Given this list of marker genes CUL2, RPS6KA3, SPICE1, MED12, HLA-E, EIF4B, CD1B, POGZ, AP2A2, STARD5, ESYT1, IFNA16, SLC7A7, ITGAL, CBX5, PCNA, EIF2B5, SOCS7, ICAM3, ATP5PO, SLC1A5, POR, VAMP8, CSRP1, CCR1, BRD3, CDH2, FRY, VAT1, FCAR, TLE5, CPVL, NDUFV1, AHCY, INTS10, OGG1 (8-oxoguanine DNA glycosylase), COMT, GNRH2, VASH1, HLA-DMB, CLSTN1, SELENOP, POLE3, MNDA, ERCC3, RPL6, STK38, PTGS1, DNASE2, ADORA3, DIAPH1, PDE1C, ERF, CTDSP2, TRIO, ITGAM, DGKZ, MLEC, RPL22, HEXA, NASP, BRCA2, NISCH, ADIPOR2, KAT2A, UQCRC2, CD163, BLMH, DOK2, SORL1, PIP4K2A, AGA, DDX28 (NCBI Gene Id 55794), TACC1, CYFIP1, ALDH5A1, IMPA2, CCR5, MED22, LTB, TAF11, SPECC1L, FSHR, SUPT4H1, TDRD3, MTCL2, MYO7A, PDLIM7, CD1D, CD14, ERP29, CNOT3, HTT, POU2F1, SRSF3, ALDOC, UBXN1, CDK3, PADI2, MUC6, GPX3, HDDC2, B3GNT2, NPTN, LAIR2, PCBP2, FOS, BLOC1S1, TLR1, AMHR2, MEGF9, SNAPC5 (NCBI Gene Id 10302), ALDH3A2, AMPD2, SELE, FCGRT, METAP1, TKT, DAB2, PBX3, PREPL, P2RY14, RPS4Y1, CNPY3, CD27, EIF4EBP1, SDHB, H2AZ1, DDX39A, WDR1, ERCC1, P2RY11, YAF2, SNRPA1, LRP1, ABCA6, PER2, VSIG4, MSH3, C3AR1, SEC14L1, ZC3HAV1, PTPRCAP, DOCK2, ACTA2, SPINK4, SERPINB8, TXNIP, FAM20B, FGL2, GART, LTA4H, HMGN2, SF1, RDH11, SLC25A12, FAM168B, PLCG2, SEC11A, STAB1, OGT, ARHGEF6, PRCP, SYNE1, ANGPTL7 (NCBI Gene Id 149217), FEN1, NME4, GLB1, SF3A3, ADGRL2, KLF4, VAV1, CIAO1, LY6G6D, MCM3AP, PABPN1, KYAT1, S100A4, PIK3CG, AP1B1, OGA, SLC35A3, STX16, P2RY6, ANKS1A, BTD, DST (dystonin), PECAM1, POLR2H, FAM3A (NCBI Gene Id 60343), SNX27, HLA-DOA, MAX (MYC associated factor X), SPIB (Spi-B transcription factor), SLC43A1, SNRNP200, IRAG2, NCF4, PRKCB, CPE, here is a description of the gene set: species: Homo sapiens Genes down-regulated in comparison of dendritic cells (DC) exposed to L. donovani versus DCs exposed to 5 worm/well B. malayi. Human Gene Set: GSE360_L_DONOVANI_VS_B_MALAYI_LOW_DOSE_DC_DN from publication Chaussabel D, Semnani RT, McDowell MA, Sacks D, Sher A, Nutman TB (PMID 12663451) Monocyte-derived dendritic cells (DC) and macrophages (MΦ) generated in vitro from the same individual blood donors were exposed to five different pathogens, and gene expression profiles were assessed by microarray analysis. Responses to Mycobacterium tuberculosis and to phylogenetically distinct protozoan (Leishmania major, L. donovani, Toxoplasma gondii) and helminth (Brugia malayi) parasites were examined, each of which produces chronic infections in humans yet vary considerably in the nature of the immune responses they trigger.